Given this list of marker genes Pde1a, Bptf, Ncoa6, Bclaf1, Kif16b, Matr3, Pms2, 1700001O22Rik, Dntt, Prkca, Mphosph9, Hirip3, Tspan1, Rdm1, Erbin, Prrg1, Pkp1, Apc, Aox4, Slc5a12, Ubxn10, Senp6, Bpnt2, here is a description of the gene set: studied in species Mus musculus Genes in the expression cluster 'ST-HSC Shared': up-regulated in short term hematopoietic stem cells (ST-HSC) from adult bone marrow and fetal liver. from publication Ivanova NB, Dimos JT, Schaniel C, Hackney JA, Moore KA, Lemischka IR (PMID 12228721) Mechanisms regulating self-renewal and cell fate decisions in mammalian stem cells are poorly understood. We determined global gene expression profiles for mouse and human hematopoietic stem cells and other stages of the hematopoietic hierarchy. Murine and human hematopoietic stem cells share a number of expressed gene products, which define key conserved regulatory pathways in this developmental system. Moreover, in the mouse, a portion of the genetic program of hematopoietic stem cells is shared with embryonic and neural stem cells. This overlapping set of gene products represents a molecular signature of stem cells. Mouse Gene Set: IVANOVA_HEMATOPOIESIS_STEM_CELL_SHORT_TERM